Given this list of marker genes ZFP37, ETF1 (eukaryotic translation termination factor 1), ATP8B2, TFAP2D, THRA, ZFX, C1orf131, ALDH6A1, KIF7, ITPR1, SMS, FLRT3, NEUROG1, SSH2, PBX3, JUN, SPEF1 (NCBI Gene Id 25876), ELF4, RNF26, MRTFA, NELFA, TMEM187, RPL17, ANGPT1, SSRP1, NDUFS8, RTL9, GSKIP, CNIH1, RBM19, TOMM40L, RGS3, CADM1, WWP2, ADGRB2, PTPN1, UTP20, CSTF3, XPO1, PHF12, PAFAH1B1, AP1G1, TRMT112, MID1, WNT4, AGRP, PDIK1L, URB1-AS1, FAM193B, FAM162A, RCC1L, RTF1, OSR2, ZBTB17, RDH10, UBE2B, ELMO1, VAX1, GFER (growth factor, augmenter of liver regeneration), YY1, MTF1, CYP26A1, EHD3, TPM4, ATP1B2, CHCHD5, WDPCP, CFDP1, TMEM178A, POLR3D, GHR, TSC1, BMI1, ZFAND3, ST3GAL3, HOXA4, FAM181B, NDUFB1 (NADH:ubiquinone oxidoreductase subunit B1), MEIS1, CPSF2, ABAT (NCBI Gene Id 731754), GNPAT, MRPL38, here is a description of the gene set: studied in species Homo sapiens Genes having at least one occurrence of the highly conserved motif M119 GGGNRMNNYCAT in the regions spanning 4 kb centered on their transcription starting sites. The motif does not match any known transcription factor binding site. from publication Xie X, Lu J, Kulbokas EJ, Golub TR, Mootha V, Lindblad-Toh K, Lander ES, Kellis M (PMID 15735639) Comprehensive identification of all functional elements encoded in the human genome is a fundamental need in biomedical research. Here, we present a comparative analysis of the human, mouse, rat and dog genomes to create a systematic catalogue of common regulatory motifs in promoters and 3' untranslated regions (3' UTRs). The promoter analysis yields 174 candidate motifs, including most previously known transcription-factor binding sites and 105 new motifs. The 3'-UTR analysis yields 106 motifs likely to be involved in post-transcriptional regulation. Nearly one-half are associated with microRNAs (miRNAs), leading to the discovery of many new miRNA genes and their likely target genes. Our results suggest that previous estimates of the number of human miRNA genes were low, and that miRNAs regulate at least 20% of human genes. The overall results provide a systematic view of gene regulation in the human, which will be refined as additional mammalian genomes become available. Human Gene Set: GGGNRMNNYCAT_UNKNOWN